The following is a description of a gene set: Human Gene Set: GOMF_CHLORIDE_ION_BINDING Binding to a chloride ion (Cl-). studied in species Homo sapiens, and this is the list of marker genes: AMY1B, NLGN4X, NPR3, WNK4, NQO2, ACE, AMY2A, AMY1A, NUDT16, CTSC, TDG, SLC22A6, LCN1, AMY1C